The following is a description of a gene set: Human Gene Set: ZNF282_TARGET_GENES species: Homo sapiens from publication Yevshin I, Sharipov R, Kolmykov S, Kondrakhin Y, Kolpakov F (PMID 30445619) Genes containing one or more binding sites for (ZNF282) in their promoter regions (TSS -1000,+100 bp) as identified by GTRD version 20.06 ChIP-seq harmonization., and this is the list of marker genes: MAP7D1, AP4B1, KPNA2, POMGNT2, BMP1, ZNF775, PDPR2P, DCLRE1B, RUNX2, LRSAM1 (leucine rich repeat and sterile alpha motif containing 1), CDC34, SIRT5, BCL2L13, TMEM191B, MDH2, AP3M2, RPS6 (NCBI Gene Id 92956), PHPT1, SSH1, UBE2E3 (NCBI Gene Id 10477), MPC2, UCP2, LIMS1, RTN4R, BNIP3, CCDC47, FOSL2, CNPY2-AS1, TLCD4, ARPC1B, DPP9-AS1, MCRIP2, GTPBP3, RPL17-C18orf32, BRD2, FIBP, RPS7, PHLPP1, CCDC12, NOC2LP1, MTIF2, MAPK6-DT, MPP3, MAP1LC3A, SLC12A2, ANO8, MIR4734, TF, EGFL7, SMG7, GOLPH3-DT, VAC14 (NCBI Gene Id 55697), SIL1, NR1D2, ELAVL1, ZFPM2-AS1, RN7SL525P, NFIA-AS1, STARD3, RHCE, BRD3, CADM1, PRKACA, PAQR9, CTDSP2, USP40 (ubiquitin specific peptidase 40), ST7-OT4, RADIL, MAD1L1, IREB2, ADRM1, PAXIP1-DT, SLC35G1 (solute carrier family 35 member G1), ATF7-NPFF, ST7, AVPI1, MRPL38, NR4A1, SHB, LINC01399, NES, PTEN, CNPPD1, RPL7A, NOC4L, JADE2, WDR38, RC3H2, TRAK2, NOL9, CYB561, CLSTN1, ENSG00000271551, BANP, LRRC28, MYH10, MPC1-DT, GPATCH3, TPR, CTXN1, RPS11, PRSS16, MYO18A, HLA-DMA, SLC25A4, TIGAR, CCNJ, CHPF, EOGT-DT, LCORL, TAS1R1, VPS13D, EIF2S3, ADO, SANBR, PLEKHH3, WAPL, KIAA1191, DVL1, SLC35E2A, MICOS10-NBL1, NEURL1B, BAX, CCDC127, RNF220, ADSS1, SYNM, ERGIC2, FOXD3-AS1, EIF2B4, DNM2, SNAP47, ABR, ZBTB12, CRELD1, MATR3, HEMK1, GPR89A, KIAA0232, ATAD2, SFXN5, THEM4, PPP4R3B, NR6A1, ISG20, TENT4A, MCUB, TPTEP1, MAML3, RPL12, SUGP1, DNAJB2 (NCBI Gene Id 3300), MRO, SP1, DAZAP1, UBE2O, TADA3, PSMA6, ANKRD28, ZNF510, STK4-DT, HISLA, NEMP2-DT, TECPR2, DEDD, MAPK8IP2, ADGRL1, USP20, OFD1, MAZ, REPS1, FAM199X, PMAIP1, TDH-AS1, NEMP2, TBCEL, TBPL1 (NCBI Gene Id 9519), CSTF1, UHRF2, FGFR3, HSF2BP, RNU6-218P, PCBD2, PLEKHH2, TFDP1, EXOC3L2, NFIC, TMCO3, NSD2, ETFA, GNB1-DT, CTBP1, SDK2, IGSF11, PANX2, POU2F2, LUC7L2, WASHC2C, CDK14, DNM1L, HGS, APOBEC3C, SMG5, RAVER2, TRPM7, THOC1, ACVR2B, TNFRSF12A, ZNF346, LPCAT1, RBM48, DARS1, AGO3, DPP9, ARHGEF12, CLTB, BCAP29, NDST2, ACVR1, UBE2E3-DT, RHBDL1, ZFYVE9 (zinc finger FYVE-type containing 9), SNX17, VPS4A, TMEM198, LARGE2, DRAP1, MED8 (mediator complex subunit 8), GPBP1, ROGDI, OBSL1, SNX5, CISD3, MICOS10, CXCL2, WDR77, KLLN, CYRIB, DIRAS1, BCAR1, MAST3, ODR4, HES2, RAI14, NDUFV2-AS1, MLST8, ZNF395, ORAI1, IL11, TESC, TNS2, APLP2 (amyloid beta precursor like protein 2), DNAJC27-AS1, KDELR3, RETREG2, MAK16, RRM2, LTBR, CYTH4, PLAG1, DNMT3B, CARHSP1, WDR73, GSE1, RPL6, NIPSNAP3B, GNB1, HDAC10, PEX10, RNVU1-26, ARHGEF19, GGA2, EIF1, ICMT, H2AZ2-DT, MGME1, PRRT2, ANKRD31, TLCD4-RWDD3, CTDSP1, TMPO, PUF60, PDGFA, OLFM2, RUNX1T1, RNF157, VSTM4, RILP, INCA1, TNS2-AS1, SMAD3, MTCL1, CCDC6, LMBR1, RPUSD1, MIR4435-2HG, KLF10, PPP4R3B-DT, NAB1, LIMD1-AS1, KLK1, ARID3A, LAMP1, SLC2A13, SNORA57, LINC00958, C11orf68, ATP13A3, ARPC4, DKKL1, ATXN2 (ataxin 2), TPD52, MYADM-AS1, TUBGCP5, VWA7 (von Willebrand factor A domain containing 7), SOCS2-AS1, FEV, SCRIB, ZZZ3, MFAP3L, KIF18B, TMEM87B, MICAL2, ZNF106, SMG7-AS1, CCDC91, FNDC3A, PIGK, ATP5PB, NPHP3-AS1, TGOLN2, SEMA4C, PGRMC2, ANKRD12 (ankyrin repeat domain 12), PDCD4, MBTPS1, SMYD2, MXI1 (NCBI Gene Id 4601), CELF1, PEX1, AP5B1, ZYG11B, MEF2A, KCNS2, UBTD1, JMJD1C, PTPN18, HMX3, LIN9, ARRDC1, VPS26A, TTC23, CLOCK, RAB3B, STAG2-AS1, SYCE1L, RNF167, ISYNA1, MAP1LC3B2, CSNK1E, AGPAT2, IL1R1, NPHP3, ARHGAP21, HNRNPU, CHIC2, SPDL1, TMEM132A, REEP6, EP400, UBR5, CIP2A, XK, CTNNBIP1, GRIK4, SEPTIN7 (NCBI Gene Id 989), PHF3, ACTN1-DT, DDX42, TFR2, DICER1-AS1, ARF3, PDXK, ACTN1, PPP1R13L, FAM83A-AS2, SF1, ZFP36L2, PLEKHJ1, RNF19A, DSCAS (DSC1/DSC2 antisense RNA), LPXN, MCAM, ZNF706, RHPN2 (rhophilin Rho GTPase binding protein 2), UPP2, TBXAS1, LINC01366, PER3, DEGS1, SEPTIN2, TRDMT1, PNMT, CD2AP, WDR37, THAP2 (NCBI Gene Id 83591), FASN, WNK4, PTGER2, PTGR3, ARC, AHI1, CDK11A, ZFP91, TMEM64, CD68, ERCC6L2-AS1, FSIP1, SNHG16, DENR, NME3, CDK12, LIG4, SHLD2, ERLIN1 (NCBI Gene Id 10613), DPYD, WAPL-DT, FNDC4, TMEM11, SPEN, PCSK4, UBTF, MMP15, POP7, SLC10A3, FBXL5 (NCBI Gene Id 26234), PRR12, TMEM229B, DHDDS, INHA, ELAC1, CAST, DYRK1A, PDE8A, STK4, TIPIN (TIMELESS interacting protein), RNF130, TNIP2, MARCHF2 (NCBI Gene Id 51257), YPEL1, H4C12, PTGES2, TLE2, NCOA4, AANAT, SUMO2, MARCHF6, NEDD1, CFAP251, CNNM3, SELENOV, NR2C2, HDAC4, C2CD2L, ZNF846, TRAPPC10, ENSG00000244791, GLIPR2, GLCE, TMEM201, OCRL, CTSA, EXOSC6, TPI1, HDAC4-AS1, CLCF1, HSPA4, MKRN2, CDK5R1, ARID1A, ORAI3, AMH, USP39, PTOV1, ZBTB14, SLC43A3, BTBD10, MMS22L, TRIM6, PRKCQ-AS1, MTCL2, CCNT1, FAM83A, DNAJC5, PPM1L-DT, WHRN, ANKRD13B, THOC1-DT, RNASEH2B, GNAO1, YWHAH (tyrosine 3-monooxygenase/tryptophan 5-monooxygenase activation protein eta), CHTF18, AGFG2, TRIM44, CYP4F3, TMC6, NOP14 (NOP14 nucleolar protein), ADAMTS3, SYNGR2, NIPSNAP3A, FAM53A, SLC35A5, PISD, TFEB, FAM76A, PRKCQ (NCBI Gene Id 5588), APOC1, ZCCHC2, MIR378A, EIF4A3, ADARB1, TM2D3, DDIT4, XPC, PYGO2, SMAD3-DT, ATXN1L, TSSK3, MYO1C, SUPT5H, CDKL1, TICAM2-AS1, ZNF83, ICA1-AS1, NOTUM, FAM111A-DT, RIN1, STX16, HK1, APOBEC3D, MNT, CANX, ADAP1, ATF7, KIF5B, ZBTB47-AS1, GSR, AKAP11, URI1, YBX1, LTBP4, ANXA2, CFL1, SGO2, ZFP30, LINC02934, EIF5, CUEDC1, NPTN, LINC01128, ZNF131, BAIAP2L1, SSBP3, RRP1B, NFIB, SYDE2, SAMD11, SLC25A11, ID2-AS1, LCOR, GORASP2, KIF18B-DT, PURA, G0S2, TUBB, TICAM2, LY6E-DT, CHAF1A, TGIF1, MAFG, MVP-DT, HMGA1, ATP2A3, EHBP1L1, NAT14, NCOA2, TNNT1 (troponin T1, slow skeletal type), TAB3, PRDX1, NLRP1, CCT8, FOXO6, SUZ12P1, DCTN2, KIF13A, RNF146, FAM72A, RASSF7, SEMA7A, COX11, HOOK3, MAPK6, QRICH1, ASXL1, ZDHHC7, DAAM1, RFC5, SLC39A3, RPS19, UVSSA, UBR3, ENTPD1-AS1, ZNF653, TBCD (NCBI Gene Id 6904), CTSZ, MARCHF10, STXBP4, SKA3, PTPMT1, SDHA, CCDC159, PTOV1-AS1 (NCBI Gene Id 100506033), H4C11, FSCN1, ZNF276, FAT1, IMPDH1 (inosine monophosphate dehydrogenase 1), STKLD1, DNAJC27 (DnaJ heat shock protein family (Hsp40) member C27), P2RX6, MIOS, HSPA9, MIR4690, KMT2C (lysine methyltransferase 2C), MMS19, PTGS1, PIK3R3, RNF207, PLEKHG4, GPR137, SIPA1, GCLM, IBA57, TMEM131L, LINC00398, CLDN6, BCOR, NUP153, SUMO3, PACSIN3, NOSIP, MINDY4, SNX9, ADNP, KIF1B, VPS37D, MIER1, ZNF22-AS1, FOXRED2, PTPRN, IBA57-DT, IER2, HIP1, TUBB2A, ME2, TMEM183A, TMEM44-AS1, SCAP, LINC02281, TMBIM1, SH2D7, MEX3D, WNK2, RALGDS, FAM131A, HSDL2-AS1, ANKRD40, LINC00938, APOBEC3B, PPP3CC, CDK17, LDB1, PPM1L, FNIP2, SRGAP2, DCAF6, DDHD2, NRBP2, DLGAP4, BEND3, PROS1, TSPYL6, DDX51, SLC8A2, PDK4-AS1, PKM, SF3A2, TUBG1, RXRA, RARA, STAU2, LTV1, PER1, LINC02569, OBSCN-AS1, TMEM191C, ATXN2L, CHTF8, MIR3667HG, KBTBD2, FGD5-AS1, CAPN2 (NCBI Gene Id 824), BCAP31, FAM135A, FSTL3, TRIM28 (NCBI Gene Id 96054), ZNF428, PPCDC, FHL3, SNAP23, RUFY3, CPTP, MBTPS1-DT, PTGES2-AS1, MEX3B, TRIM6-TRIM34, AKAP1, CLCN7, CERCAM, SEC62, ITM2C, HBG2, ENSG00000246792, RNF170, TMEM79, PYGO2-AS1, SGK3, ZYG11A, KLHL17, RAB26, AKTIP, SSR4P1, CRK, ZNF268, GCSH, CCDC57, CSKMT, CSNK1G2, LENEP, SLC25A10, AAAS, GCLC, UGP2, CHMP2A, CDKN1C, NR2F6, ZNF671, ICMT-DT, EHD1, OR51B5, SZT2, CLTA, ZDHHC8, CREM, MIR638, APBA2, MANBAL, IL5, ATPAF1, DDX59, ADRA2B, MICALL1, UROD, NDUFB2, DHRS4L2, ZMIZ1-AS1, COX7B, GAS8, INKA2, ATN1, KCNH5, BAMBI, NAA60, SENP5, ARPC4-TTLL3, RAD23B, BAD, TACC1, CDKN2C (cyclin dependent kinase inhibitor 2C), PUM2, SLC29A1, ARID1B, REPIN1, MANSC1, GUK1, LSM14B, ALAD, CARHSP1-DT, SOCS3 (NCBI Gene Id 9021), NFE2, PTPN4, HS3ST3B1, TPTEP2, SMAD2 (NCBI Gene Id 654050), ABHD13, STYXL1, NDUFB2-AS1, ANKS1B, ENPP1, TSPAN3, MTG1, FOXK2, IRF2BP1, TCP11L1, RCL1, U2SURP, FAM20B, TEF, SNORD58B, ENSG00000260592, SEPTIN7-DT, TMEM145, JADE3, SF1-DT, POLR1G, MRPL57, FOXD3, REV3L, STIM1, RTN4RL2, RPL17, TRAJ23, C8orf82, SLC2A4RG, WASL, FBXO6, OTUB2, FAM21FP, MAPK8, ILVBL, ARL16, APLP1, ZFC3H1, PDIA2, MYADM, FERMT3, CS, PCGF3, ATG3, RETREG3, CNIH2, PRICKLE3, CNP, QSER1, DOCK9-DT, MAPK8IP3, SELENOS, MYPOP, SOCS2, PIM3, USP54, C1RL-AS1, LYL1, ISLR2, NOL4L, LINC02593 (NCBI Gene Id 284598), RAD50, ASIC4, PRR5, CCDC136, AKAP8, FHL1P1, ELOVL1, NCAPG, CEBPD, AKAP1-DT, MAPK14, WASL-DT, SURF4, SACM1L, STAG2, TRAF3IP2-AS1, VPS9D1, RNF207-AS1, ACCS (NCBI Gene Id 84680), PAXIP1, C1RL, ZNF236, GGNBP2, DCAF16, SLC36A4, C11orf21, TESC-AS1, DAO, WNT11, LINC00115, ODC1-DT, TATDN2, USP24, MARCHF7, LINC02327, GEMIN8, NAPRT, MACO1, TAL1 (TAL bHLH transcription factor 1, erythroid differentiation factor), RBM39, SCAMP5, PHF1, KIF1C, ALDH4A1, PROKR1, NCAPG2, PAFAH1B3, FABP5P3, CD2AP-DT, TMEM18, BCORL1 (BCL6 corepressor like 1), ZMIZ1, RFK, NOC2L, UTP4, CALM3, HIPK2, HMG20A, SRCAP, ENSG00000271860, RAB6B, PSMD5, GRK4, COMT, NBPF25P, PHF19 (NCBI Gene Id 26147), HDLBP (high density lipoprotein binding protein), NIFK (NCBI Gene Id 84365), UIMC1, PLAU, TPBGL-AS1, GIGYF2, ZNF641, HSD11B1-AS1, DCUN1D2, ACTB, VDAC3, ERCC6L2, RABGGTA, TAB2, AP2A2, ENSG00000253986, IGF2BP3, KRAS, CBX4, ODC1, STRADB, MICOS10-DT, ANTKMT, ATP13A3-DT, ATAD3A, DESI2, NHSL3, AFG3L2, PPP5D1P, ACP5, RN7SL2, MIDEAS, HMGB3P22, KLF3, KAZALD1, ZNF513, DOCK9, HDAC6, USP13, NFE2L2, LIN28B, DPP7, LINC03072, MYL5 (myosin light chain 5), GNAO1-DT, CHCHD7, AURKA, APOC1P1, SLC44A1, HSD17B8, C11orf98, DOC2A, PRKAR2B, RFX1, PERP, CCND1, TSG101, CERS2, SLC40A1, PTPN11, FLNA, HCG27 (NCBI Gene Id 282955), MICU2, VAX2, PGAM5, CTBP1-DT, PAQR9-AS1, MPC1, STK32B, STRIP1 (striatin interacting protein 1), KCTD18, HBE1, MFSD14CP, GOLGA8B, AURKAIP1, BRPF1, ZFP91-CNTF, CTTN-DT, MED22, MIB2, ANK1 (ankyrin 1), FGD4, PPP1R14A, HPF1, CLEC16A, MAU2, JUP, NEURL2, FAM111A, BZW1, GET4, RAB9A, AKT3, RUNX1, QKI, NIN, DZIP3, MAP2K2 (NCBI Gene Id 85511), LMNTD2, DMXL1-DT, IRF1, EOGT, VEZF1, TEAD1, ANKFY1, CRPPA-AS1, INTS11, SLC35D2, MIOS-DT, BMI1, ANPEP, TSHZ1, LINC01029, ESRRA, TMSB10, PKIA, CARINH, SUPT4H1, TPRKB, GXYLT1, NMUR1, TEX38, FAM200B, RHOT2, NEDD4L, STX16-NPEPL1, JAK1, DONSON, GOLPH3, TSNARE1, PLEKHA1, SLC12A2-DT, DICER1, CDS1, NAA35, BICRAL (BICRA like chromatin remodeling complex associated protein), TRAPPC2, ABCD1, IST1, FBXW11, SYCP2, METTL21A, DMXL1, HCG14 (NCBI Gene Id 414760)